The following is a description of a gene set: Human Gene Set: GSE22282_HYPOXIA_VS_NORMOXIA_MYELOID_DC_UP studied in species Homo sapiens Dendritic cells (DCs) are professional antigen-presenting cells whose activity is intrinsically linked to the microenvironment. Hypoxia is a condition of low oxygen tension occurring in inflammatory tissues that creates a special microenvironment conditioning cell physiology. We studied the effects of hypoxia on the differentiation of human monocytes into DCs and maturation into mature DCs. Mature DCs were differentiated in vitro from human monocytes under normoxic or hypoxic conditions and the gene expression profile was determined. from publication Bosco MC, Pierobon D, Blengio F, Raggi F, Vanni C, Gattorno M, Eva A, Novelli F, Cappello P, Giovarelli M, Varesio L (PMID 21148811) Genes up-regulated in myeloid dendritic cells: hypoxia versus normoxia., and this is the list of marker genes: DDX39B, MC2R, CINP, CCL5, TNFAIP3, MMP14, RPF2, ZMIZ1, ABRACL, PHEX, ACY3, MRM3, TMEM132D, MLH1, SAA1, MRPL52, ACOD1, GPR84, CHCHD4, CYB5R1, TMA16, CBFB, TRAPPC2 (trafficking protein particle complex subunit 2), HYOU1, ECE2, NT5C3B, EHD1, NKRF (NCBI Gene Id 55922), ENOPH1, S100A6, SOD2, MYD88, KCNIP4, NFKBIE, CTSZ, CH25H, GLRB, HIVEP3, PHF5A (PHD finger protein 5A), CAV2, ETNK2, JUNB, CD38, CAV1, NOVA1, C3, NEDD8, LIG3, PRDX5, CIMIP5, FLRT3, PLD2, POLR1E, MRPL12, HNRNPD, HTR4, TOR1AIP2, SNRPA, SERTAD1, FPR2, ELMO1, CXCL17, IFT57, CCDC9, MDH2, EXOSC2, PRELID3A, UBE2T, ARID1A, TNIP1, EPHA5 (NCBI Gene Id 7304), RAPGEF5, TMEM186, FAM241A, TRAF3, MARCKSL1, MVP, MBTD1, RNF19B, CCRL2, RPGRIP1, NCF4, EDC3, VPS29, RPS6KA6, STAT1, AMMECR1, DYNLRB1, CALML4, DCP2, GSK3B, PPA1, ACSL5, ICAM1, N4BP1, TASOR2, CDIPT, PSMG3, SLC25A20, CNTNAP4, RNF185, CD302, RNF10, IGSF6, CXCL16, FDPS, SNRPB, HSPA1B, CAMKK2, GOLM2, CLCNKB, PSME2, PABPN1, HP, PHB1 (prohibitin 1), SLC16A10, KCNA2, TENT4A, CXCL3, POLR2E, SLC25A29, NREP, ATP5MC3, MMP12, MCEMP1, SLC31A1, FMNL2, BUB3, PCDHB13, PCCA, RAB1B, DOCK7, SELENOV, RAB20, PLA2G7, PRC1, UBE2F, ADSS1, KBTBD13, CLEC4E, PEA15, MTMR14, NUPR1, ZFYVE9, RNF19A, TTLL11, SH3BP2, LRRC3B, KDELR2, CCNB3, NXPH2, SMPDL3B, PSMA3, NFKBIA, IL1RN, HRK (harakiri, BCL2 interacting protein), COPE, GTPBP3, PDE4DIP, PLAT, DDX49, UMOD, ACTRT3, MYO10, PDE4B, MYMK, VSTM2A, PTGER4, CXCL1, STX11, DEFB119, HSFY2, MLLT6, CERS6, CLEC5A (NCBI Gene Id 23601), SELE, FDFT1 (NCBI Gene Id 2222), TLR2, LMO4, FOXP3, MVD, PPDPF, HES5, TREH (NCBI Gene Id 11181), NUBP1, SDC1, C1orf141, PSMD10, HDDC2, TULP3, TNF, SLC2A6, FBRS, LRCH2, CFAP90, GSTM2, AGPAT4 (NCBI Gene Id 56895), KCNN4 (NCBI Gene Id 3783), NADK, NAB1